Given this list of marker genes CSPG5, B4GALT7, NCAN, HSPG2, BCAN, SDC2, SDC4, SDC1, GPC4, GPC5, UXS1, B3GAT1, GPC1, AGRN, GPC2, BGN, DCN, B3GAT3, B3GAT2, B3GALT6, CSPG4, GPC6, XYLT2, GPC3, SDC3, XYLT1, VCAN, here is a description of the gene set: studied in species Homo sapiens Human Gene Set: REACTOME_A_TETRASACCHARIDE_LINKER_SEQUENCE_IS_REQUIRED_FOR_GAG_SYNTHESIS A tetrasaccharide linker sequence is required for GAG synthesis